The following is a description of a gene set: Genes predicted to be targets of miRBase v22 microRNA mmu_miR_6383 in miRDB v6.0 with MirTarget v4 prediction scores > 80 (high confidence targets). from publication Chen Y, Wang X (PMID 31504780) Mouse Gene Set: MIR_6383 species: Mus musculus, and this is the list of marker genes: Susd6, Pcdhac1, Slc16a9, Sfmbt1, Pdcd1lg2, Ankrd33b, Ptpn21, E2f1, Zfp148, Myf5, Tmcc3, Rufy2, Prepl, Sumf1, Luzp1, Usp24, Tnks2, Pcdha8, Dpysl5, Fbxl5 (NCBI Gene Id 242960), Pxk, Osm, Pkd2, Tmem123, Cc2d1a, Slc17a8, Rundc1, Hook3, Txnip, Bcl11b, Col19a1, Rgmb, Col4a3, Aak1, Nr2c2, Smoc1 (SPARC related  modular calcium binding 1), Armc8 (NCBI Gene Id 74125), Pkd1, Npas2, Kpna2, Ss18l1, Dpysl2, Brms1l, Fbxo21, Dnajc24, Ccdc71l, Tspan9, Vldlr, Mfap3l, Zbtb41, Pirb, Has2 (hyaluronan synthase 2), Dock4, Purb, M6pr, Ano5, Wdr37, Nfat5, Dusp2, Ism2, Tnks1bp1, Zfp236 (zinc finger protein 236), Enpp5, Rab11fip5, Rgma, Mknk2, Pex5l, Map3k12, Cep57 (centrosomal protein 57), Wfs1, Rab3gap1 (RAB3 GTPase activating protein subunit 1), Plekha3, Trim3, 1600012H06Rik, Pde3b, Bcl2l11, Pcdha6, Btg3, E2f5, Prr14l, Ezh1, Kcnb1, Ptpn3, Sprn, Arhgef11, Nup35, Ulk1, Sybu, Rsrp1, Ankrd13c, Fam13c, Sertad2, Fastk, Ankrd9, Kif5a, Osr1, Kat2b, St6galnac3, Slc2a4, Map3k14 (mitogen-activated protein kinase kinase kinase 14), Rab5b, Unk, Bnc2, Trpv6, Ppp1r3e, Cep120, Slc25a40, Pcdha7, Mastl, Rab30, Wasf1, Usp46, Smim5, Prr15, Usp3, Egln3, Oxr1, Kdm2a, Celsr2, Pcdha10, Mapre3, Slc22a23, Pfkp, Scn1a, Ankrd17, Rab22a, Retreg2, Arhgap26, Arhgef10, Dennd10, Zdhhc8, Creb1, Ano3, Trip10, Ncoa3, Fbxo28, Ints14, Elk3, Foxj2, Gab1, St8sia2, Srcin1, App, Frmd6, Rbbp7 (retinoblastoma binding protein 7, chromatin remodeling factor), Dcbld2, Ldlrap1, Atl3, Rps6ka5, Abcg4, Nedd4l, Akt3, Atxn7l1, Fibin, Eif4a2, Sh3pxd2a, Uri1, Gpr137c, Gxylt1, Fam117b, Kif23, B3galt2, Suco, Rasd1, Polr3g, Slc6a9, Tnfaip1, Fcho2, Marchf8, Nek9, Gon4l, Ythdf3, Dmtf1, Fndc3b, Mkrn1, Limk1, Mtmr3, Btbd10, Stk11 (NCBI Gene Id 97678), Stk38, Bnip2, Slc24a2, Rsbn1, Tars2, Kcnk10, Nagk, Zbtb9, Zdhhc1, Gpr137b, Trappc2, Rab10, Frs2, Pcdha3, Rab8b, Cald1, Creb5, Reps2, Pthlh, Med12l, Tph1, Atg16l1, Hlf (NCBI Gene Id 217082), Rp2, Ormdl3, S1pr1, Sar1b, Col4a4, Fsd1l, Zfp9, Pafah1b1, Nrip3, Mapre1, Arhgap12, Tmem127, Tasor, Zfyve26, Slain2, Tafa1, Gabbr2, Sall3, Septin2, Plxdc2 (plexin domain containing 2), Psd, Gid4, Pkd2l2, Timp2, Slc49a4, Bmpr2, Rps6ka4, Klf9 (NCBI Gene Id 70273), Mapk4, Rnf6, Rasl11b, Tiam1, Pls1, Gramd1a, Laptm4a, Tet1, Dgkq, Map3k13 (NCBI Gene Id 71751), Rock2, Tsg101, Lama3, Pbx3, Tfb2m, Idua, Arhgap1, Dnal1 (dynein, axonemal, light chain 1), Npas3, Zfand4, Pcdha12, Mink1, Dcaf8 (DDB1 and CUL4 associated factor 8), Ogfod2, Trip11, Camta2, Hs3st5, Cdc37l1, Retreg3, Fbxo31, Napepld, Irf2bp2 (interferon regulatory factor 2 binding protein 2), Spred1, Gpr63, Jazf1, Srpk2, Pcdha4, P2rx4, Unc80 (NCBI Gene Id 78608), Uevld, Jpt1, Bahd1, Klhl28, Ginm1, Rgs17, Cdca7, Tppp, Ndel1, Mosmo, Agfg2, Camta1, Reep3, Slc16a6, Fnbp1l, Ccng2, Lrch1, Lypd6, Il25, Iqsec2, Dab2 (disabled 2, mitogen-responsive phosphoprotein), Pcdha1, Zbtb18, Mcl1, Ppp1r15b, Topors, Snx8, Chd9, Ugdh, Ube2q2, Fgd5, Tbcel, Tmem64, Aktip, Rb1 (RB transcriptional corepressor 1), Vash2, Stxbp5, Map7, Slc12a7, Hycc2, F3, Kmt2b, Ube3c, Pnpla1, Camk2n2, Pak5, Zfp512b, Smad5, Ddhd2, Pitpna, Crot, Prrg1, Chmp4c, Slc17a7, Pcdha11, Foxj3, Sobp, Rnf128, Gnb5, Map6d1, Kmt2a, Bicd2, Midn, Ppp1r3b, Cfl2, Tbc1d8b, Bbx, Igsf10, Lratd2, Vangl1, Plekha7, Zhx2, Zfp367, Itpripl2, Znfx1, Gad2, Usp32 (ubiquitin specific peptidase 32), Mfn2, Acsl4, Adam9, Cast, Epha4, C2cd2, Pcsk5 (NCBI Gene Id 18552), Fam219b, Crk, Panx2, Mex3d, Lrp8, Fjx1, Glis3, Xrn1, Tbc1d9, Rap2c, Rbl2, Eri1, Lpgat1, Derl2, Pcdha5, Csnk1g1, Dennd5b, Sh3bp2, Spopl, Irf9, Fzd3, Rps6ka1, Cep97, Gpc6, Ahnak, Atg14, Unkl, Afg1l, Csrnp3, Mylip, Dsg4, Tbc1d12, Slc18a2, Tmed8, Neurog3, Zc3h12c, Pcdha2, Phip, Rs1, Sorl1, Ankib1, 2510009E07Rik, Skor1, Hbp1, Slc40a1 (NCBI Gene Id 56067), Rab12, St3gal1, Clock, Slc31a2, Nr4a3, 6430548M08Rik, Kif3b, Apcdd1, Nabp1, Abhd5, Tgfbr2, Ptpn4, Atad2, Rnf150, Lrrc55, Socs6, Rasgrf2, Neurog2, Itgb8, Zfp704, Ankrd52, Rab33b, Npat, Sqstm1, Ntng1, Strip2, Pgm2l1, Naa30, Rassf2, Epha7, Pcdha9, Mospd2, Klf11, Fat2, Pkn2, Wdfy3, Kcnq2, Trappc14, Fat4, Zfp661, Abca1, Nbea, Rapgefl1, Gbf1, Lhx6, Coro2b, Lima1, Flt1, Fyco1 (NCBI Gene Id 70204), Atxn1l, Arhgef18, Olfm1, Myt1l, Cd69, Nanos1, Snx16, Mier1, Chrm2, Zfp91, Stx6 (syntaxin 6), Gosr1, Cnot7, Ddhd1, Rnf2 (ring finger protein 2), Zfpm2, Tmem267, U2surp, Map3k8, Nckap5, Akap13, Tnfrsf21, Smyd1 (NCBI Gene Id 97290), Ficd, Rcan3, Smoc2, Ppp1r21, Sall1, Slc25a36, Ago1, Pcdhac2, Ahrr, Mier2, Sema7a, Clip4, Pdgfra, Heg1, Arhgap35, Cbln4, Map3k2, Acer2, Zfp827, Rhoc, Sos1, Mmp24, Srgap1, Trim36, Rb1cc1, Zfp800, Arid4b, Crybg3, Pgbd5, Cmpk1, Rest, Cnot6l, Ptchd4, Fgd4, Sema4b, Sash1, Tle4, Zbtb4, Ssh2, Tanc2, St6galnac6, Golga1